The following is a description of a gene set: from publication He P, Lim K, Sun D, Pett JP, Jeng Q, Polanski K, Dong Z, Bolt L, Richardson L, Mamanova L, Dabrowska M, Wilbrey-Clark A, Madissoon E, Tuong ZK, Dann E, Suo C, Goh I, Yoshida M, Nikolić MZ, Janes SM, He X, Barker RA, Teichmann SA, Marioni JC, Meyer KB, Rawlins EL (PMID 36493756) Human Gene Set: HE_LIM_SUN_FETAL_LUNG_C1_EARLY_STALK_CELL species: Homo sapiens Early stalk, and this is the list of marker genes: ESPL1, BRCA1, FANCB, PKN3, MMP16, CHST6, CNTNAP2, HNRNPA1L3, FGFR1, CDC25B, SGO2, SSX2IP, HIC2, KIF15, CDT1, CHAF1B, ESCO2, CTNND2, OIP5, BFSP1, POLE, EXOSC6, ARG2, CENPN, ATP11C, XXYLT1, PBK, PAQR4, UQCRHL, BRCA2, DIAPH3, GJC1, TRNP1, SLF1, ERI1, H3-5, TNFAIP8L1, TPX2, CDK1, CHAF1A, GSTCD (NCBI Gene Id 79807), FAM111B, CHEK2, CHEK1, ATP2A1-AS1, PARD6G, BUB1B, NUDT11, LARP6, PARVB, GLB1L2, SANBR, ANO8, KIF18B, DSN1, USP49, CENPM, LINC01224, HMSD, ZGRF1, CENPK, DEPDC1, PRR11, KCMF1, H2BC9, TIPIN (NCBI Gene Id 54962), PARPBP, MKI67, RND3, CEP57L1, TTR, MELK, RND1, NLRP1, STON2, GEMIN2, FJX1, SLC16A14 (NCBI Gene Id 151473), APOA1, EME1, CCDC34, H2BC11, E2F7, DHFR, CDCA5, PLEKHA8, VAV3, MMS22L, PLXDC2, EEF2KMT, SFMBT1, SKA3, GMPPB (GDP-mannose pyrophosphorylase B), CDH6, MCM6, FANCA, BAG2 (BAG cochaperone 2), MND1, RECQL4, DDB2, CITED4, FAT3, PDF, LRRC49, POLA2, ARHGAP22, EDIL3, RTKN2, SCD, CTPS1, NR2F2-AS1, RMI1, PLCB3, ABHD3, TACC3, TCF7, SGO1, PAIP2B, FEN1, ATAD5, MAN1A1, KIF23, DKK3, PGP, ACOT7, COL1A2, PLK4, PSME4, GRK6, LOXL3, TONSL, CDC20, PUDP, KCNN1, KDM2B, LTBP1, CHRNA5, CDC7, TESMIN, PCYT2, ACVR1B, PRTG, SHCBP1, ATAD2, RAD54B (RAD54 homolog B), MYO9B, POLA1, ORC1, RBL1, CADM2, MPZ, HSPA2, XRCC2, ARHGAP11A, CENPJ, F2R, TSPAN5, PKMYT1, NEK2, PLK1, CORO1C, SNAI1, LIMK1, ARID3B, ZWILCH, DNA2, FAM216A, PASK, CCNJ, TRIP13 (NCBI Gene Id 9319), CDC6 (NCBI Gene Id 990), KIF20A, WDR86, RAB11FIP4, NUF2, COL26A1, CEP55, BYSL, KIF3C, TEAD4, UACA, HRH2, AEN, ARRDC1-AS1, CFAP20DC, RNF175, PRKAR2B, TEDC2, CCNA2, SHISAL2B, WDR76, LINGO1, CDC45, UBE2T, CFAP119 (cilia and flagella associated protein 119), KCNMB4, ASF1B, SPINDOC, CENPL, SARDH, GAS2L3, NEIL3, CCDC18, TUBB4A, NFE2L3, SPDL1, C6orf226, KNL1, C14orf132, LIN52, TFRC, LRATD1, CCNJL, HBEGF, ST8SIA2, KIF11, SLC39A14, ALDH1B1, DONSON, ADAMTS7, JAM3, PRKCA, NUAK1, DDX11, MYBL2, MAP7D1, ANK2, SFXN5, HSD17B14, RRS1, ADM, CIP2A, SGK1, SMIM10, BORA, IL17RD, STRA6, GNPNAT1, CD83, TTLL5, BIRC5, RFC4, YKT6, ATAD3A, FANCI, APBA2, NEURL1B, CDC25C, FAXC, KIF18A, GLCE, THNSL2, GPX3, PGAM5, TUBB3, MDC1, ZNF730 (zinc finger protein 730), FSD1, RACGAP1, TMEFF1, ALYREF, ZSWIM6, APLP1, KHDRBS3 (KH RNA binding domain containing, signal transduction associated 3), NPM3, NUSAP1, RTTN, HROB, APOC1, AIFM2, CENPW, HUNK, GCH1 (NCBI Gene Id 93984), ACAP3, INSIG1, NIBAN1 (niban apoptosis regulator 1), GASK1B, CEP128, NDC80, FAM83D, CCDC9, RANGAP1, KIF2C, TEDC1, AURKA, TMEM37, CCNF, UHRF1, FADS2, HMMR, BLM, PNMA3, SH3PXD2B, NDC1, H1-1, CCNE2, RAD51AP1 (NCBI Gene Id 10635), KIF21B (kinesin family member 21B), TNFAIP3, PIM1, CENPA, CTU1, TCEAL7, CLSPN, LIN28B, CNFN, CSNK2A3 (NCBI Gene Id 283106), PSRC1, DSCC1, TDP1 (NCBI Gene Id 55775), TENT5B, PHYHIPL, FIRRM, NDE1, NCAPG2, IGDCC3, H3C15, NUP205, H3C2, LOXL1, ORC6, STIL, CENPE, ZNF788P, FANCD2, H2AC11, CENPH, MCM8, PRIM1, PHLDA1, CDKN3, KIF14, PMAIP1, TRAIP, WDHD1, HSPB8, USP43, STARD9, MYCN, PLA2G3, TIMELESS, GREB1 (growth regulating estrogen receptor binding 1, NCBI Gene Id 9687), GUCY1A2, ICA1L, RFC5, CDO1, H3C12, PLAUR, MCM4, GADD45A, GALNT6, PGAM4, PDXP, NRXN3, FBXO5, FGD6, AGPAT4 (NCBI Gene Id 56895), PPP1R14A, CDCA8, FREM3, ZNF850, H3C8, HDC, NES, ILDR2, MAD2L1, TSPAN2 (NCBI Gene Id 10100), LRR1, SLC12A5, RCOR2, PCDH17, HJURP, COL9A1 (NCBI Gene Id 1297), FGF13, DTL, CENPU, CPXM1, IQCJ-SCHIP1, CDCA2, CDCA3, SLC27A2, SYNJ2, ARHGEF39, VCAN, ARHGAP19, MSI1, TTI2, GAS2L1, TK1, SKA1, CADM4 (cell adhesion molecule 4), LIX1, MXD3, MTHFD1L, SLC6A8, LINC01315, PCLO, GADD45G, AURKB, SERPINE2, CENPO, TMEM178A, RRM2, RELT, PYGL, NUP62CL, DERL3, ECT2, CCNQ, POC1A, ZNF442, HAUS8, PIF1, SACS, ETNK2, MTA1-DT, RARRES2, CBS, CTXN1, CTSV, RAD54L, PDE7A, TRMT6, TTK, CRABP1, EFNB1, MEX3D, PSMC3IP, PRIM2, ALPL, SPC25, SUV39H1, KIFC1, CKAP2L, NPPC, H2AC20, C6orf141, LAMA1, ELAVL4, PRADC1, GRB10, GALNT16, RBPMS2, DLX3, NEXN, CTHRC1, CBX2, PPM1L, KLHL5, GYPC, BUB1, SLC5A3, E2F5, ANLN, SPA17, PIMREG, CAPN6, CLEC11A, HOMER3, ABCC1, SERAC1, FBXL19, PARD6G-AS1, CCNYL1, RNF144A, GPC2, SUV39H2, PCGF6, H3C14, DUSP8, GLDC, LDLRAD3, SFR1, TOP2A, KNTC1, PCSK4, H2AC13, DLGAP5, HSPA4L, KNSTRN, PCDH18 (NCBI Gene Id 54510), E2F1, SLC29A1, GPSM2, SRSF12, VRK1, TROAP, BRIP1, RAD54L2, IHH, MASTL, LDLR, LRP2, MTHFD2, SPECC1, FOXM1, MOCS1, GINS1, CYTH3, STOX1 (NCBI Gene Id 219736), MAP1B, PLCL2, FZD4, LRRC20, DLEU2, RFWD3, SALL4, HSPA6, UBE2C, CRISPLD2, NCAPG, TAF5, CENATAC, SLC5A6, CENPP, SPC24, EXO1, CCNB2, CENPF, SPAG5, WASF1, GAS2, KIT, KIF4A, FUOM, PRELID3A, H2AC14, FSD1L, PACC1, MVK (NCBI Gene Id 4598), INCENP, GINS4, ELOVL6, BRI3BP, DDC, SREBF1, SYT11 (synaptotagmin 11), MSANTD3, MPV17L2, HES6, RIPPLY3, RFX6, STXBP6, TTF2, XRCC3, NCAPD2, CCDC150, COCH, TICRR, MICA, TOPBP1, DEPDC1B, ASPM, RND2, CDC25A, C5orf34, CD200, ZNF724, ZNF695, NCAPH, MCM10, POLE2, TPM2, TIGAR, PAQR5, FANCG, GTSE1